Given this list of marker genes HOXA11, MXI1, FOSB, CCND2, MYC, TRAF3, RFNG, IRF4, DTX2, PIK3CG, FZD6, NCSTN, MIB1, STAT5A, BTG3, FANCA, POU2AF1, PRDM1, VSX2, MBD1, AKT1 (NCBI Gene Id 207), PRKCD, GADD45B (growth arrest and DNA damage inducible beta), XBP1, BMI1 (NCBI Gene Id 648), IRF6, PSEN2, TNFSF13B, SOCS2, HES3, HOXC13, here is a description of the gene set: Cluster 2 of genes distinguishing among different B lymphocyte neoplasms. Human Gene Set: SHIN_B_CELL_LYMPHOMA_CLUSTER_2 Aside from Myc-activating translocations characteristic of plasmacytomas (PCT), little is known about genetic factors and signaling pathways responsible for the development of spontaneous B-cell lineage lymphomas of mice. Here, we characterized the transcriptional profiles of PCT, centroblastic diffuse large B-cell lymphomas (CBL), and high-grade splenic marginal zone B-cell lymphoma (MZL++) using high-throughput quantitative reverse transcription-PCR. Expression profiles of CBL and MZL++ were strikingly similar and quite unlike that of PCT. Among the genes expressed at significantly higher levels by PCT were a number involved in NOTCH signaling, a finding supported by gene set enrichment analyses of microarray data. To investigate the importance of this pathway, NOTCH signaling was blocked in PCT cell lines by treatment with a gamma-secretase inhibitor (GSI) or transduction of a dominant-negative mutant of MAML1. These treatments resulted in reduced expression of NOTCH transcriptional targets in association with impaired proliferation and increased apoptosis. GSI treatment of transformed plasma cells in a primary PCT also induced apoptosis. These results integrate NOTCH activation with oncogenic signaling pathways downstream of translocated Myc in the pathogenesis of mouse PCT, two signaling pathways also implicated in development of human multiple myeloma and T-cell lymphoblastic lymphoma. from publication Shin DM, Shaffer DJ, Wang H, Roopenian DC, Morse HC 3rd (PMID 19010892) species: Mus musculus